Given this list of marker genes VEGFA, ALDOA, PDGFB, UGP2 (UDP-glucose pyrophosphorylase 2), GPC3, HOXB9, DDIT3, HK1, TMEM45A, IER3, GALK1, PPFIA4, BCL2, PGK1, CAV1, VLDLR, GPC4, PPARGC1A, CASP6, MT2A, IGFBP3, LARGE1, GBE1, CDKN1B, SLC2A3, TPBG, IL6, DUSP1, TKTL1, ETS1, PYGM, CHST2, PAM, IDS, SLC25A1, CCN1, GRHPR, PKLR, PIM1, NDST1, F3, TES, STC2, ZNF292, SAP30, CXCR4, B4GALNT2, PFKL, ADM, EGFR, VHL, GCNT2, PNRC1, PLAC8, FOS, NAGK (NCBI Gene Id 55577), HK2, GAPDH, PFKFB3, ATP7A, LDHC, CHST3, PDK3, SULT2B1, PLAUR, PGAM2, NOCT, XPNPEP1, JUN, KIF5A, IGFBP1, TPD52, CP, LOX, AMPD3, SDC4, LDHA, GAPDHS, CA12, INHA (NCBI Gene Id 3623), SLC37A4, ENO3, MAFF, PGM1, LXN, STC1, SLC2A1, GLRX, NDRG1, ALDOC, TGFBI, PCK1, AKAP12, SELENBP1, ATF3, HS3ST1, SLC6A6 (solute carrier family 6 member 6), MXI1, ZFP36, CAVIN1, MYH9, SIAH2, BGN (biglycan), CITED2, FBP1, GAA, ACKR3, ANKZF1, EFNA3, TGM2, SDC3, GCK, PRKCA, SDC2, ALDOB, MT1E, PLIN2, GPI, SRPX, NCAN, NEDD4L, KDELR3, ISG20, DPYSL4, CAVIN3, DDIT4, CCNG2, ERO1A, CSRP2, P4HA2, NDST2, TGFB3, MAP3K1, HSPA5, BNIP3L, HMOX1, DTNA, PGM2, HDLBP, KLHL24 (kelch like family member 24), CDKN1C, RBPJ, TNFAIP3, RORA, PFKP, LALBA, BCAN, B3GALT6, PPP1R15A, EXT1, PHKG1, ANXA2, PRDX5 (peroxiredoxin 5), P4HA1, HAS1, BHLHE40, IRS2, PDK1, EFNA1 (ephrin A1), BTG1, DCN, SERPINE1, JMJD6, COL5A1, ENO2, AK4, CDKN1A, GPC1, PGF, STBD1, NR3C1, PPP1R3C, CCN5, NFIL3, FOXO3, SCARB1, KLF7, FOSL2, TPST2, BRS3, EDN2, CCN2, S100A4, ADORA2B, WSB1, PKP1, ERRFI1, ANGPTL4, KDM3A, TIPARP, TPI1, GYS1, RRAGD, KLF6, MIF, HEXA, ILVBL, FAM162A, ENO1, SLC2A5 (solute carrier family 2 member 5), here is a description of the gene set: species: Homo sapiens Human Gene Set: HALLMARK_HYPOXIA Genes up-regulated in response to low oxygen levels (hypoxia). from publication Liberzon A, Birger C, Thorvaldsdóttir H, Ghandi M, Mesirov JP, Tamayo P (PMID 26771021)